The following is a description of a gene set: Human Gene Set: GOMF_MHC_CLASS_II_RECEPTOR_ACTIVITY studied in species Homo sapiens Combining with an MHC class II protein complex and transmitting the signal from one side of the membrane to the other to initiate a change in cell activity., and this is the list of marker genes: HLA-DOA, HLA-DOB, HLA-DQB1, HLA-DQA1, HLA-DRB3, HLA-DPA1, HLA-DRB1 (NCBI Gene Id 730415), HLA-DQA2, HLA-DQB2, HLA-DRA